Given this list of marker genes MDM2, TRIP11, EGLN1, ZFPM2, PTK7, NSD2, TGFBR2, BMPR1A, MIR17HG, MATR3, NPRL3, PDE2A, ACVR1, MDM4, HEY1, LUZP1, WNT5A, NKX2-5, TBX3, BMPR2, FGFRL1, HOXA13 (NCBI Gene Id 3209), GATA4, CITED2, NOS3, HEG1, RBPJ, DAND5, ID2, RBM15, FZD2, TBX5, CCN1, DCTN5 (NCBI Gene Id 84516), PRDM1, TGFB2, ZFPM1, GATA3, XIRP2, PROX1, HES1, TGFBR3, AP2B1, STRA6, BMP4, FGFR2, VANGL2, SMAD6, SLIT3, SUFU, HEYL, LRP2, GJA5, SMAD7, FRS2 (NCBI Gene Id 10818), HECTD1, SOX11, ADAMTS19, PITX2, NOTCH1, SLIT2, NOG, PAX8, SALL1, ROBO2, HEY2, APLNR, LMO4, SAV1, SOX4, FZD1, ROBO1, WNT11, MIR1-1, CNTRL, TGFBR1, SALL4, SMAD4, here is a description of the gene set: Human Gene Set: GOBP_VENTRICULAR_SEPTUM_DEVELOPMENT species: Homo sapiens The progression of the ventricular septum over time from its formation to the mature structure.